The following is a description of a gene set: Human Gene Set: KEGG_MEDICUS_ENV_FACTOR_NNK_NNN_TO_PI3K_SIGNALING_PATHWAY_N01350 species: Homo sapiens NNK/NNN to PI3K signaling pathway. Pathway ID: N01350. Pathway type: Env factor. Pathway class: nt06214 PI3K signaling. Pathway Definition from KEGG: (NNK,NNN) -> CHRNA9 -> PI3K -> PIP3 -> AKT -> (ESR1/2,AP1) => (CHRNA9,CCND3), and this is the list of marker genes: AKT3, FOS, AKT2, JUN, CHRNA9, CCND3, AKT1, PIK3CD, ESR1, PIK3CA, PIK3CB, ESR2